The following is a description of a gene set: from publication Busslinger GA, Weusten BLA, Bogte A, Begthel H, Brosens LAA, Clevers H (PMID 33691112) Human Gene Set: BUSSLINGER_DUODENAL_PANETH_CELLS species: Homo sapiens, and this is the list of marker genes: LYZ, DEFA5, SPINK4, LCN2, REG3A, CLCA1, ITLN2, FCGBP, PRSS1, MUC2, GUCA2A, TFF3, DEFA6, ITLN1, PLA2G2A